The following is a description of a gene set: part of: Toll Like Receptor 3 (TLR3) Cascade Reactome Pathway: TLR3-mediated TICAM1-dependent programmed cell death TLR3 and TLR4 trigger TRIF(TICAM1)-dependent programmed cell death in various human and mouse cells (Kalai M et al. 2002; Han KJ et al. 2004; Kaiser WJ and Offermann MK 2005; Estornes Y et al. 2012; He S et al. 2011). Apoptosis is a prevalent form of programmed cell death and is mediated by the activation of a set of caspases. In addition to apoptosis, TLR3/TLR4 activation induces RIP3-dependent necroptosis. These two programmed cell-death pathways may suppress each other. When the caspase activity is impaired or inhibited, certain cell types switch the apoptotic death program to necroptosis in response to various stimuli (TNF, Fas, viral infection and other stress stimuli) (Kalai M et al. 2002; Weber A et al. 2010; Feoktistova M et al. 2011, Tenev et al 2011). species: Homo sapiens, and this is the list of marker genes: RIPK3, RIPK1, TLR3, FADD, CASP8, TICAM1